Given this list of marker genes Ildr1, Tcea3, Tsc22d3, Htra3, Hoxa1, Vgll2, Ush1g, Artn, Tead2, Ihh, Mpig6b, Slc34a2, Mcoln2, Sbspon, Sphk1, Arid3c, Sowahd, Tcp11, Fam83g, Twist1, Lrrc15, Atoh1, Galr2, Kcnq1, Acan, Aqp3, Emid1, Mapk13, Wnt9b, Itgb4, Flnc, Shisa3, Slc6a4, Hck, Tnfsf11, Nr4a3, Loxl2, Lhx6, Eomes, Bmp8a, Vwa2, Vsx1, Prph (peripherin), Foxa1, Dusp9, Chst5, Ppic, Hrob, Il27ra, Lpar3, Pitx2, Comp, Oxt, Crabp1, Gdf6, Nrtn, Foxi2, Rab37, Tmprss2, Col2a1, here is a description of the gene set: from publication Meissner A, Mikkelsen TS, Gu H, Wernig M, Hanna J, Sivachenko A, Zhang X, Bernstein BE, Nusbaum C, Jaffe DB, Gnirke A, Jaenisch R, Lander ES (PMID 18600261) Genes with high-CpG-density promoters (HCP) bearing bivalent histone H3 dimethylation mark at K4 (H3K4me2) and trimethlation mark at K27 (H3K27me3) in brain. Mouse Gene Set: MEISSNER_BRAIN_HCP_WITH_H3K4ME2_AND_H3K27ME3 species: Mus musculus DNA methylation is essential for normal development and has been implicated in many pathologies including cancer. Our knowledge about the genome-wide distribution of DNA methylation, how it changes during cellular differentiation and how it relates to histone methylation and other chromatin modifications in mammals remains limited. Here we report the generation and analysis of genome-scale DNA methylation profiles at nucleotide resolution in mammalian cells. Using high-throughput reduced representation bisulphite sequencing and single-molecule-based sequencing, we generated DNA methylation maps covering most CpG islands, and a representative sampling of conserved non-coding elements, transposons and other genomic features, for mouse embryonic stem cells, embryonic-stem-cell-derived and primary neural cells, and eight other primary tissues. Several key findings emerge from the data. First, DNA methylation patterns are better correlated with histone methylation patterns than with the underlying genome sequence context. Second, methylation of CpGs are dynamic epigenetic marks that undergo extensive changes during cellular differentiation, particularly in regulatory regions outside of core promoters. Third, analysis of embryonic-stem-cell-derived and primary cells reveals that 'weak' CpG islands associated with a specific set of developmentally regulated genes undergo aberrant hypermethylation during extended proliferation in vitro, in a pattern reminiscent of that reported in some primary tumours. More generally, the results establish reduced representation bisulphite sequencing as a powerful technology for epigenetic profiling of cell populations relevant to developmental biology, cancer and regenerative medicine.